The following is a description of a gene set: Mouse Gene Set: GOBP_MACROPHAGE_CYTOKINE_PRODUCTION studied in species Mus musculus The appearance of a macrophage cytokine due to biosynthesis or secretion following a cellular stimulus, resulting in an increase in its intracellular or extracellular levels., and this is the list of marker genes: Psg22 (NCBI Gene Id 243862), Sirt1, Wnt5a, Il1b, Cd74, Litaf, Pycard, Card9, H2-M3, Laptm5, Plcg2, Gas6, Cd36, Trim55, Tgfb3, Gprc5b, Atg9a, Nod1, Nod2, Tirap, Acp5, Ifng, Tgfb1, Cuedc2, Rtn4, Mapkapk2, Prg2, Mir324, Twist2, Hspa12a, Ube2j1, Casp1, Irak3, Nlrx1, Myd88, Gorasp2, Sucnr1, Tlr4, Ripk2, Tlr3, Ash1l, Epx, Casp4, Sema7a, Twist1, Panx1, Psen2, Ticam1, Spon2 (spondin 2, extracellular matrix protein), Tgfb2, Nlrp3, Tlr7, P2rx7 (purinergic receptor P2X, ligand-gated ion channel, 7), Tlr2, Axl